The following is a description of a gene set: Human Gene Set: MIR4694_3P from publication Chen Y, Wang X (PMID 31504780) studied in species Homo sapiens Genes predicted to be targets of miRBase v22 microRNA hsa-miR-4694-3p in miRDB v6.0 with MirTarget v4 prediction scores > 80 (high confidence targets)., and this is the list of marker genes: SLC2A2, KDM5A, SYBU, GPSM2, ERGIC1, RANBP9, APAF1, ATP6V1D, DCP2, SMNDC1, LIX1, TAF9B, CNOT6L (CCR4-NOT transcription complex subunit 6 like), TET3, CAPZA2, SCN2A, CXXC4, TMEM182, PWWP3B, ADAM23, CD274, MOB1A, CACNG2, ATF2, NFYC, LPAR1, LYZL2 (lysozyme like 2), F3, OPRM1, ARB2A, AUTS2, PRPF38B, ARPC2, KNOP1, CISD1, SMARCA2, STAC, CFLAR, RGS8, CCDC179, VPS53, CEP20, FHIP2A, MAN1A2, VEPH1, HNRNPR, WIPF3, TAOK3, TMCC2, AIG1, EIF2A (NCBI Gene Id 83939), MEF2C, SMAD5, ANKRD20A1, SLC4A7, ARSJ, LGI1, LCTL, RAB30, MESD, OMD, HMG20A, MAP2 (NCBI Gene Id 4133), TMEM128, GBP4, MAP3K13, PTPN4, GLS, CASP3, PLEKHA5, TMEM150A, FGF14, ARL15, RASGRP3, CIMIP6, GPC6 (NCBI Gene Id 10082), ELL2, MTR, ERRFI1, RORA, TMEM248, UBE2Q2, SLC10A7, PCNP, DHX35, ZDHHC23, PPP2R3A, MBL2, DOCK7, DNAJC18, KHSRP, MARK1, EXOC5 (exocyst complex component 5), OTUD1, RBSN, SGTB, C11orf87, KLC1, NUP153, TPK1, ACBD7, CLMP, ADAM7, TNRC6B, RFX7, COG5, TSHZ3, EIF2AK3, MAML3, C1orf21 (NCBI Gene Id 81563), NEK4, AMMECR1, CDK5R2, C21orf91, SKIL, SHOC2, WAC, BEND3, VSX2, POLR1E, SELENOP, CTNNA2, TMUB2, EXPH5, CD80, LPCAT2, B3GALNT2, RSAD2, CMTM6, TPD52L3, HSD17B13, NUFIP2, NEUROD4, CNDP1, CAMK4, SCGB2A1, SLC38A2, RDX, PSMA7, CORO1C, SEC23A, ZBTB10, FGF13, SLC6A8 (solute carrier family 6 member 8), RYR2, PCSK5, SEPTIN2, KDM2B, COL21A1, NFAT5, TASL, DNAJC22, PTPRB, AVPR1A, CLCN3, TECRL, CAMTA1, ABCC4, FBXL2, LYZL1 (lysozyme like 1), MED1, HERC4, SYNJ1, FBXO25, TOX3, ADAM12 (NCBI Gene Id 8038), BCL11A, ZIC3, SEZ6L, RAPGEF2 (NCBI Gene Id 9693), ZNF567, UBE2W, CLOCK, GABRA4, CHST9, CYB5B, PRICKLE2, SGPP1, RBBP9, ANKRD20A3P, STC2, CEP43, FKRP, MYSM1, CCDC170, C1S, MAGEB18, LPCAT1, ATP11AUN (ATP11A upstream neighbor lncRNA), PTPRS, AMOT, NTRK2, MAP3K1, RBBP5, ZNF76, CWC27, GPATCH11, MAP4K2, SVEP1, CPD, TBPL1, FXR1, PPM1A, SLC25A16, TMEM94, SS18L1, MTX3, TMEFF2, NXT2, CMTM2, MFAP1, GOLGA1 (NCBI Gene Id 2800), G3BP2, TIAL1, HECW2, METAP1D, TRHDE, IFIT1B, KRAS, PALM2AKAP2, PHIP, FRK, SOS1, CIBAR1, GTPBP10, HYCC2, CDH11 (NCBI Gene Id 1009), VSIG10, UBP1, SMIM14, TGIF1, FCHO2, HJV, EBF3, YIPF6, PRLR, PANK3, SLC12A2, DAZL, ANXA5, CREB5, NIPBL, DCUN1D3, ACVR2A, MS4A1, FAM180A, HOPX, DLC1, MFSD8, METTL21A, AMER2, DET1, GMNC, ZNF441, CENPM, TANC2, ANKRD20A4P, PRKAA1 (protein kinase AMP-activated catalytic subunit alpha 1), CCDC186, DLG1, TM9SF3, GEM, SLC13A3, KCNIP4, NRIP1, ARID4B, CAMK1D, TNPO1, ACVR1C, ABCB5, SPOCK3, PLEKHF2, SYF2, LSM8, VASH2, CYLD, IL6ST, CCDC169, WT1, NEUROD1, RPRD1A, XBP1, GIMAP8, TOMM20L, ZC3H12C, DEDD, CCR1, PTGR2, IKZF1, PAK2, HOXA1, BRWD1, CHIC1, NEIL3, GLRB, PRKACB, RCOR1, RTKN2, DIDO1, MTSS1, MYT1, RERE, PTPRG, NETO1, STOX2, DCK, VPS8, SORL1, ANKRD20A2P, DLG2, TOMM20